The following is a description of a gene set: Genes down-regulated in comparison of dendritic cells (DC) stimulated with LPS (TLR4 agonist) at 12 h versus DC cells stimulated with Gardiquimod (TLR7 agonist) at 12 h. Human Gene Set: GSE17721_LPS_VS_GARDIQUIMOD_12H_BMDC_DN from publication Amit I, Garber M, Chevrier N, Leite AP, Donner Y, Eisenhaure T, Guttman M, Grenier JK, Li W, Zuk O, Schubert LA, Birditt B, Shay T, Goren A, Zhang X, Smith Z, Deering R, McDonald RC, Cabili M, Bernstein BE, Rinn JL, Meissner A, Root DE, Hacohen N, Regev A (PMID 19729616) mouse primary BMDCs were stimulated with tlr ligands and gene expression changes were profiled on Affymetrix arrays studied in species Homo sapiens, and this is the list of marker genes: TMEM119 (transmembrane protein 119), CTSK, GHDC, OXCT1, CCT3, SDHC (succinate dehydrogenase complex subunit C), TOM1, CARMIL1, CABLES2, ADPGK, CHMP1A, SMPX, DNAJC18, SPTAN1, HERPUD1, AARS1, NPM1, SCD, PSPC1, RPS10 (ribosomal protein S10), ATP11C, MEF2A, CCDC82, WNT6, CABP2, STK17B, PHPT1, EEF1D, KRTAP15-1, SRFBP1, ADGRE1, RASSF8, SLC22A4, HINT1, ETFRF1, CEP250, GAK, FGD4, TMEM165, SLC20A1, NANP, TAF9, GMEB1, MYL10, MIS18A, SYNJ2, SLAIN2, ST6GALNAC2, CYB5A, PRKD3, ZZZ3, CLIP1, SLF1, NT5DC3, TRMT112, EPS15L1, SDC2, UBE2E3, WASHC2A, HSD17B12, IL17RA, POLR2F, MMP12, METAP2, CKAP4, GTF3A, CD72, TEX10, FAM216A, KCTD12, PRKCH, HGSNAT, IL1RL2, NCF2, PALD1, DAP3, PON2, SLC16A1, UBE2C, RABAC1, FGD6, PSRC1, ADAM17, NAPA, SLC30A5, RASA2, NPPC, TFRC, SDC1, CNTROB, BCL6, APEX2, LAS1L, RPL9, GLRX, SC5D, SQOR, CINP, SPCS3, HJURP, GARS1, SELENOS, CDR2, POFUT2, C5orf52, NDUFV2, ABHD17C, LACTB2, MTF2, SMAP1, ASTN1, METTL13, HSD17B7, UBE2B, RHOB, IDH2, HTR2B, CLK2, SCT, EGR1, DHX15, MINDY1, ART4, SLC46A3, SEC11A, EIF1AX, AKR1B15, CMTM3, SLC35F5, TFB2M, PCGF6, SLC31A1, SORT1, MAK16, UQCRB, ANXA5, LPGAT1, PIP5K1A, GPR137B, EEF1E1, FANCF, CX3CR1, SERPINB1, FUT9, SLC2A1, CLEC4D, SLC25A29 (solute carrier family 25 member 29), RTN3, SPIDR, PBX3, MAPKAPK5, RPS16, NDUFB2, ARHGEF3, PNPLA7, RPLP2, APRT, ACTG2, WLS, UAP1L1, SRPK2, MMP8, POLD4, NDUFB8, CSTB, ZMPSTE24, MAGOHB, SNX15 (NCBI Gene Id 29907), GOLGA5, PLAUR, AKIRIN2, RRAGC, SLC5A1, RAI14, TGFBI, TNFRSF21, ATP6V0B (NCBI Gene Id 533), MCUB, VIPR1, EDN1, NADK, HP, LPL, SPCS2, RRAS, PSEN2, NUP37, PCK2, CRY1 (cryptochrome circadian regulator 1), CACNA1F, DHRS7, NEAT1, ITPR2, TREM1, BPNT1, DNAJC9, PTGR1, RIOX2, SLC35B4